Given this list of marker genes Tbx18, Epcam, Ovol1, Sulf1, Sox9, Pdgfb, Hs3st3a1, Akr1b1, Vcan (versican), Ren1 (renin 1 structural), Pax8, Tgfb1, Gdf6, Sulf2, Kank2, Lrrk2, Cyp4a32, Osr2, Bmi1, Snx17, Nup160, Mecom, Angpt1, Emx2, Pkd1 (polycystin 1, transient receptor potential channel interacting), Lin28a, Npnt, Nid1, Clcnka, Wfs1, Prdm1, Nle1, Pdgfra, Pkd2, Edn1, Ddc, Anxa4, Gatm, Nphp3, Ptcd2, Fgf1, Lgr5, Sfrp1, Foxd1, Fras1, Cflar, Cc2d2a, Hey1, Irx3, Mir216b, Ilk, Tet2, Ctnnbip1, Hs2st1, Tmem59l, Gcnt1, Nkx3-1, Dact2 (dishevelled-binding antagonist of beta-catenin 2), Has2, Traf3ip1, Rara, Grem1, Cyp4a10, Basp1, Plxnd1 (NCBI Gene Id 67784), Cxcr4, Rdh10, Gpr4, Ift88, Timeless, Wnt4, Adamts1, Id3, Kif26b, Dchs1, Itga3, Myo1e, Ctnnb1, Bmp2, Osr1, Smad6, Aqp2, Npr2, Pou3f3, Rpgrip1l, Mir216a, Wnt1, Pdgfrb, Dchs2, Zng1, Notch2, Klf15, Cited2, Agtr1a, Smad1, Six1, Irx1, Ret, Mtss1, Ptpro, Bdnf, Gsta3, Acvr2b, Smad2, Hpgd, Nfia, Mir125b-2, Prom1, Foxf1, Fat4, Lif, Wnt5a, Ace, Lgr4, Pdgfd, Six4 (NCBI Gene Id 20474), Gdf11, Nek1, Apaf1, Pspn, Enpep (glutamyl aminopeptidase), Myocd, Kif3a, Ednrb, Slit2, Fbn1, Spry1, Itgb3, Tmem67, Epha4, Cyp4a31, Mpv17, Nphs1, Hes5, Apc (NCBI Gene Id 11789), Smad7, Ednra, Egr1, Ctnnd1, Fgf10 (fibroblast growth factor 10), Smo, Il6ra, Nup107, Bmp4, Col4a4, Casp9, Crlf1, Pcsk5, Hnf1b, Lrp4, Ap1b1, Pax2, Tacstd2, Ptk7, Mmp9, Pcnt (pericentrin (kendrin)), Gfra1, Smad3, Smad4, Wnt11, Gzf1, Sox17, BC028528, Cplane1, Vangl2, Podxl, Efnb2, Wnt2b, Cfh, Cd34, Sec61a1, Adamts16, Fgfr2, Frem2, Tek, Greb1l, Odc1, Myc, Maged1, Nog, Hmgcs2, Notch3, Dspp, Cdkn1c, Pbx1, Slc5a1, Nphs2, Cat, Arid5b, Serpinb7, Stra6, Pygo1, Tfap2b, Calb1, Robo1, Ass1, Ift20, Ctsh, Sdc1, Traf3ip2, Klhl3, Ampd2, Pcsk9, Tsc1, Actn4, Fgf2, Smad5, Rhpn1 (rhophilin, Rho GTPase binding protein 1), Cxcr2, Mme, Qrich1, Sall1, Nf1, Ttc8, Sgpl1, Psap, Agt, Cux1, Aph1c, Mef2c, Prkx, Ptch1, Rbp4, Bmper, Dync2h1, Pdgfa, Dlg5, Upk3a, Acta2, Ctns, Adamts6, Cep290, Zbtb14, Col4a1, Ift25, Ift27, Prickle1, Aqp11, Lama5, Zfp950, C3ar1, Glis2, Cyp26b1, Sox11, Tcf21, Invs (inversin), Fgf8, Trex1 (three prime repair exonuclease 1), Yap1, Wt1, Angpt2, Hs3st3b1, Enpp1, Kcnj8, C1galt1, Amer1, Aldh1a2, Cyp4a14, Erbb4, Bcl2l11, Bloc1s6, Ppp3ca, Flcn (NCBI Gene Id 216805), Cd2ap, Gimap6, Epha7, Wnk4, Robo2, Mir330, Commd5, Eya1, Umod, Rarb, Kirrel3, Foxj1 (NCBI Gene Id 15223), Cd44, Sdc4, Mmp17, Sim1, Cd24a, Tns2, Nrp1, Dll1, Agtr2, Slc22a1, Magi2, Prox1, Mpst (NCBI Gene Id 246221), Id2, Tgfb2, Tgfbr1, Hdac5, Tshz3, Ahr, Rhoa, Ext1, Rrm2b (NCBI Gene Id 382985), Cyp4a30b, Bmp6, Arg2, Six2, Irx2, Zmpste24, Comt, Wnt6, Gpc3, Hoxc11, Gli2, Tfap2a, Vegfa, Aqp1, Hoxd11, Notch1, Ifng, Pkhd1, Wdpcp, Serpinf1, Foxc1, Heyl, Lamb2, Bmp10, Mir217, Jag1, Fgfr1, Mir125b-1, Lrp2, Nup85, Bcl2, Cyp4a29, Fmn1, Wnt9b, Pds5a (NCBI Gene Id 71521), Iqgap1, Gli3, Wwtr1, Lzts2, Hc, Shh, Wnt7b, Hoxa11, Gdnf (NCBI Gene Id 14573), Hes1, Itga8, Bag6, Lhx1, Adipoq, Slc22a6, Schip1, Cited1 (Cbp/p300-interacting transactivator with Glu/Asp-rich carboxy-terminal domain 1), Acat1, Hoxb7, Hspa8, Sox8, Cyp4a12b, Jmjd6, Cer1, Anks6, Aph1a, Dtnbp1, Sox4, Fadd, Kcnj1, Ndufs6, Bmp7, Tbc1d32 (NCBI Gene Id 544696), Nup133, Ap2b1, Bax, Cys1, Cntrl, Bicc1, Cyp4a12a, Gcnt3, Abcc2, Spp1, Ezh2, Hells, Dlg1, Pygo2, Stat1, Gcnt4, Asxl1, Foxc2, Col4a3, Agtr1b, Pgf, Slc12a1, Smad9 (SMAD family member 9), Plce1, Arl3, Gata3, Rgn, Tiparp, here is a description of the gene set: The process whose specific outcome is the progression of the renal system over time, from its formation to the mature structure. The renal system maintains fluid balance and contributes to electrolyte balance, acid/base balance, and disposal of nitrogenous waste products. In humans, the renal system comprises a pair of kidneys, a pair of ureters, urinary bladder, urethra, sphincter muscle and associated blood vessels. Mouse Gene Set: GOBP_RENAL_SYSTEM_DEVELOPMENT species: Mus musculus